Given this list of marker genes Ankrd13c (NCBI Gene Id 99810), Kdelr2, Hspa5, Kdelr3, Grik5, Sppl2c, Frey1, Fkrp, Insig2, Gja1, Os9, Kdelr1, Rer1, Insig1, here is a description of the gene set: Any process in which a protein is maintained in the endoplasmic reticulum and prevented from moving elsewhere. These include sequestration within the endoplasmic reticulum, protein stabilization to prevent transport elsewhere and the active retrieval of proteins that escape the endoplasmic reticulum. Mouse Gene Set: GOBP_MAINTENANCE_OF_PROTEIN_LOCALIZATION_IN_ENDOPLASMIC_RETICULUM species: Mus musculus